The following is a description of a gene set: An endocytosis process in which cell surface receptors ensure specificity of transport. A specific receptor on the cell surface binds tightly to the extracellular macromolecule (the ligand) that it recognizes; the plasma-membrane region containing the receptor-ligand complex then undergoes endocytosis, forming a transport vesicle containing the receptor-ligand complex and excluding most other plasma-membrane proteins. Receptor-mediated endocytosis generally occurs via clathrin-coated pits and vesicles. Mouse Gene Set: GOBP_RECEPTOR_MEDIATED_ENDOCYTOSIS studied in species Mus musculus, and this is the list of marker genes: Pard3, Sdcbp, Cubn, Apela, Fnbp1l (NCBI Gene Id 99918), Rab11fip5, Fcgr2b, Apoc3, Fcmr, Scrib, Grk4, Ramp3, Usp46, Pick1, Fcgr4, Vac14, Wdr54, Gria1, Bmp2k, Itgam, Ralbp1, Angpt1, Cd14 (CD14 antigen), Mx2, Susd4 (NCBI Gene Id 98456), Insr, Synj1, Clta, Cttn, Ntf3, Sgip1, Fcer2a, Ramp2, Cntn2, Wasl, Neu3, Dnm2, Hap1, Ahi1, Smap1, Lmbrd1, Tbc1d5, Atad1, Dmbt1, Apoe, Ap2a2, Unc119, Vegfa, Tpcn2, Rin3, Ighe, Itsn2, Apoc2l, Eps15, Itgb3 (NCBI Gene Id 268495), Arhgap27, Cd44, Rspo1, Fchsd2, Lyve1, Nsf, Sdc1, Snap91, Rabgef1, Ccdc32, Ins2, Apln, Scarb2, Snx1, Wnt3a, Cblb, Rabep1, Hip1r, Rab5a, Cap1, Magi2, Fcho2, Pip5k1c, Gpr107, Gak, Atxn2, Lrp1, Ldlr, Pld2, Anxa2, Tmem108, Msr1, Ap3m1, Clec9a, Plk2, Sorl1, Il4, Egf (epidermal growth factor), Lpar1, Rala, Itgb2, Tgfbr2, Dlg4, Ins1, Ccr7, Pcsk9, Apoc2, Trf, Snx9, Ap2b1, Sh3gl3, Hpse, Flot1, Dnajc6, Inpp5f, Nedd4, Ramp1, Mdm2, Clu, Ush1g, Adipoq, Tamalin, Drd2, Cd2ap, Arap1, Lmbr1l, Cav3, Plxnb2 (plexin B2), Syk, Nlgn3, Grk3, Ccl19, Kif3a, Arr3, Ankrd13d, Ap2s1 (NCBI Gene Id 232910), Lrp2, Drd3, Pikfyve, Dnajc13, Tspan7, Cltc, B2m, Cxcr2, Ralb (v-ral simian leukemia viral oncogene B), Cbl, Lrrtm1, Dgkd, Cd9, Adm, Sele, Rab31, Hfe, Iqsec1, Cltb, Ezr (NCBI Gene Id 97496), Ankrd13b (NCBI Gene Id 268445), Mkln1, Hamp, Arc, Ston2, Napb, Prkca, Scyl2, Siglech, Marco, Hmmr, Slc9b2, Gsg1l, Lilrb4b, Bicd1, Arf1, Lrrtm2, Ptpn5, Dab2, Cd81, Itsn1, Amn, Canx, Ache, Cxcl16, Plcg2, Cd300a (NCBI Gene Id 217303), Itgb1, Ptger3, Myo6, Ap2a1, Fcgr1, Efnb2, Nrg1, App, Lrp6, Tnk2, Vldlr, Dtnbp1, H1f1, Ghr, Fcho1 (FCH domain only 1), Aplnr (NCBI Gene Id 23796), Necab2, Cxcr1, Ankrd13a, Sirt2, Cd63, Rnf220, Dll1, Hpca (NCBI Gene Id 15444), Lilrb4a, Arrb1, Hspg2, Ppt1, Arrb2, Numb (NCBI Gene Id 18222), Apoc1, Grb2, Grk2, Ifitm3, Calcrl, Dnm3, Wasf1, Serpine1, Ceacam2, Rnasek, Drd4, Ap2m1, Cav2, Ophn1, Hamp2, Snx17 (sorting nexin 17), Rab21, Ldlrad3, Itgav, Akap5, Ldlrap1, C3, Sh3gl2, Ulk1, Ppp3r1, Lrpap1, Cav1, Gas7, Cln3, Micall1, Ubqln2, Ncdn, Syt17, Sfrp4, Vtn (vitronectin), Abca2, Tfrc, Snca, Sh3glb2, Ston1, Slc9a3, Ackr3, Pacsin1, Ccl21a, Mrc1, Fcer1g, Atp5f1b, Itch, Syt11, Caly, Nedd4l, Stab2 (NCBI Gene Id 192188), Hgs, Ceacam1, Fmr1, AU040320 (expressed sequence AU040320), Cd36, Dnm1, Hip1, Pla2r1, Hnrnpk (NCBI Gene Id 15387), Tfr2, Picalm, Adrb2, Grem1, Aak1, Synj2bp, Sag (NCBI Gene Id 20215), Siglec1, Rnf216, Gria2, Entrep1, Mtmr2, Dkk1, Itga4